Given this list of marker genes ABI2, ABLIM2, SPEF1, VAV2, WNT1, VIL1, MSTN, MTSS2, SRC, TWF1, PHPT1, SRGAP2, PIK3R1, ABLIM3, MIR196A1, ARPC2, ARHGEF4, PTPRO, WASF1, EPHA2, NUP85, PLCE1, MYO9B, ACTR3, RREB1, ARHGEF6, PIK3CA, HSP90AA1, ARPIN, WHAMM, ABI1, OCLN, ENPP2, WAS, ABLIM1, ITGB1 (NCBI Gene Id 3688), VCL, CYFIP1, KANK1, VAV3, NCKAP1, CDH13, CDC42, S1PR1, ABI3, SLIT2, PDPN, CORO1C (coronin 1C), CARMIL1, PLEKHO1, P2RY12, AJUBA, AUTS2, FER, WASF3, CFL1, GOLPH3, AVIL, KIT (NCBI Gene Id 5086), NCK2, CLRN1 (clarin 1), PARVB, CTTN, FSCN1, PLXNB3, ARHGEF7, MTOR, CD44, TWF2, BIN3, SPATA13, SH2B1, RHOD, CCDC88A, RAC2, SNX2, NCK1, RAC1, MIR214, SNX1, CARMIL2, ACTR2, CAPZB, AKIRIN1, FRMD7, HRG, DMTN, ARFIP2, WASF2, CORO1B, BRK1, here is a description of the gene set: Human Gene Set: GOBP_LAMELLIPODIUM_ORGANIZATION A process that is carried out at the cellular level which results in the assembly, arrangement of constituent parts, or disassembly of a lamellipodium. A lamellipodium is a thin sheetlike process extended by the leading edge of a crawling fibroblast; contains a dense meshwork of actin filaments. species: Homo sapiens